Given this list of marker genes FGFR1, NTN4, TNF, FGF7, BTBD7, PDGFA, FGF10, HGF, SNAI2, here is a description of the gene set: Human Gene Set: GOBP_REGULATION_OF_BRANCHING_INVOLVED_IN_SALIVARY_GLAND_MORPHOGENESIS species: Homo sapiens Any process that modulates the rate, frequency, or extent of branching morphogenesis in the salivary gland epithelium.